The following is a description of a gene set: studied in species Homo sapiens Genes having at least one occurrence of the motif TGRCCTTG in the regions spanning 4 kb centered on their transcription starting sites. This matches the SF1 transcription factor binding site V$SF1_Q6 (v7.4 TRANSFAC). Human Gene Set: SF1_Q6, and this is the list of marker genes: FBXO2, ALDOA, STRN, MTSS2, SLC30A3, ADAMTSL5, ZCCHC14 (zinc finger CCHC-type containing 14), CS, AMPD3, AK2, CKB, ATP5F1C, ATP5MC1, ACTR1A (actin related protein 1A), BRME1, GPBP1L1, PTPN5, CHGA, MTCH2, ATP6V1B1, SAFB, SMCO4, INSR, TBC1D15, SMG5, SLC2A4, CATSPER2, MPC2, CDHR1, FBXW4, SOCS4, ARFGAP2, ANKRD13A, DNAJC11 (DnaJ heat shock protein family (Hsp40) member C11), ACSBG1, SV2A, XYLT1, PPM1E, GIPC2, MYOM3, KIF5A, RILP, FBXO21, IDH3A, KIAA0586, PDIA3, MED26, TIMM8B, SUMO2, RHCG, CCDC92, ATP1B1, ITGA3, COMTD1, APBB1, CHD2, DEXI, TNRC6A, MSI2, OR10A5, MGST3, NAA25, RGS4, STARD13, NAV1, NTF3, ST20-AS1, FGF9, CYP46A1, UBL3, LRFN5, ZDHHC7, ATP1A4, RASGRP2, SIK3, MAL, PPP2R1A, TUBB4A, EMC8, THRAP3, SRSF4, UNC119, LINC01567, FBXO44, CNTN2, SPC24, PABPC4, NCDN, NXPH4 (neurexophilin 4), CDH16, RPH3A, ANKRD9, LDB3, RASAL1, MADD, MNT, MEF2D, VAMP2, SRCIN1, ZRANB1, KCNC1, EPN3, ESRRA, MTNAP1, SIK2, SDHD, SORL1, CACNB2, HDAC1, VASP, FSTL3, ATP5F1B, CKMT1B, RAB11FIP5, CTSD, SLC37A2, TPPP3, KCNK1, HNF1B, POLG, DHRS11, ST8SIA5, HOXC13, HTN1, MACROD1, SCNN1G, BCL3, MTX1, VCL, WBP1L, TIMM9, TOMM40, EFNB3, OTUB1, CCNE1, SPAG9, KLHL36, SDHB, CX3CL1, RYR3, CHAT, PRPSAP1, CTDSPL2, ABHD3, RPRD2, ELAVL3, KIN, RNF19B, GIT2, TOM1L2, MRPL48, ZNF644, RAB3A, IMMT, HOXC10, CASQ2, CLUH, GPR52, EIF3A, ST8SIA1, PLCB3, LINC01089, DNAJA2, SYT17, ATP5MC3, TAOK2, ARF3, MPRIP, THBS3, DRC3, FBH1, AMY2A, KIRREL3, C11orf68, TSC1, UNC5B, KPNA6, SLITRK1 (SLIT and NTRK like family member 1), RIPOR1, HSPBP1, STAC2, NDRG2, CAMK2G, VSNL1, BUB1B, KDM5A, USP8, STARD5, RANBP10, PIK3C2B (NCBI Gene Id 5287), CLPTM1, PRKAA2, HSPD1, NXPH3, AFG3L2, ST3GAL5, MAPK8IP3, NRXN2, FBXL22, FAM81A, STX1B, ZNF664, TRAP1, ATP6V0C, ABTB2, PRRC2C, GDPD1, NAA40, CNTF, RAB35 (NCBI Gene Id 11021), CLC, YY1AP1, KANSL3, PPP4R3A, EPN2, THRA, ABAT, MTX2, RHOT1, XPO6, PANK1, PPTC7, HAS3, TLCD5, VDAC2, ZNF768, RBMS1, OGDHL, MAP4K2, TMEM79, EPS8L2, DIRAS1, TTLL7, NDUFS8, TNNI1, SUCLA2, MIDEAS, LUC7L3, FBRS, SEMA7A, KCNG4 (potassium voltage-gated channel modifier subfamily G member 4), KLK15, RELT (NCBI Gene Id 84957), PDHX, WDR72, FNDC5, GABARAPL1, DRAP1, PLEKHA1, ENSG00000291228, NEBL, TBX6, FBXL19, COX5B, VCF1 (VCP nuclear cofactor family member 1), KIRREL3-AS3, IPO7, HCN4, COX4I1, RGS7